Given this list of marker genes Akr1c13, Nmrk2, Apob, Bco1, Vkorc1, Slc25a42, Tcn2, Qprt, Slc25a19 (NCBI Gene Id 67283), Pnlip, Naxd, Gpihbp1, Lrp10, Gch1, Sdc3, Mthfr, Akr1c21, Vnn1, Naxe, Cd38, Calm1, Nadsyn1, Pts, Mmachc, Gchfr, Lrp12, Akr1c20, Slc25a16, Lpl, Gpc3, Acp5, Pnpo, Akr1c18, Vkorc1l1, Pank3, Coasy, Ubiad1, Rbp2, Aco1, Nnmt, Mocs3, Folr2, Mccc2, Akr1c14, Sdc1, Flad1, Mocos, Bco2, Coq7, Cblif, Pdss2, Akr1c6, Ttpa, Slc19a1, Apoc2, Abcd4, Btd, Nudt12, Mtrr, Tpk1, Slc22a13, Apoc3, Nmnat3, Akr1b10, Naprt, Slc2a1, Apoe, Pdzd11, Lrp1, Apoa2, Gm19410, Slc52a3, Mthfd2, Rbp4, Lrp8, Apoa4, Slc5a6 (solute carrier family 5 (sodium-dependent vitamin transporter), member 6), Coq2, Nmrk1, Gpc2, Slc5a8, Apoa1, Mmab, Rbp1, Slc25a32, here is a description of the gene set: Reactome Pathway: Metabolism of vitamins and cofactors electronically inferred by orthology from the curated human pathway part of: Metabolism species: Mus musculus This event has been computationally inferred from an event that has been demonstrated in another species.<p>The inference is based on the homology mapping from PANTHER. Briefly, reactions for which all involved PhysicalEntities (in input, output and catalyst) have a mapped orthologue/paralogue (for complexes at least 75% of components must have a mapping) are inferred to the other species.